Given this list of marker genes GNG2, PRKACA, GNG8 (NCBI Gene Id 94235), ADCY6, GNB4, GNG3, ADCY5, ADCY1, ADCY4, ADCY8, GNG11, GNG13, GNB2, GNG4, PRKACG, PRKACB, ADCY2, GNG12, ADCY3, GNG7, PRKAR2B, GCG, GNB3, ADCY9, GCGR, PRKAR2A, ADCY7, GNAS, GNB1, GNG10, GNG5, PRKAR1B, PRKAR1A, here is a description of the gene set: studied in species Homo sapiens Glucagon signaling in metabolic regulation Human Gene Set: REACTOME_GLUCAGON_SIGNALING_IN_METABOLIC_REGULATION